Given this list of marker genes MT-ND3, AP3B2, PCDH15, NEK2 (NIMA related kinase 2), TOPORS, RP2, FDXR, PEX19, IMPDH1, PANK2, IFT27, PRPH2, FOXJ1, MT-ND6, HSD17B10, HGSNAT, ZNF513, MYO6, ATP5F1A, CTSD, MAPKAPK3, CEP290, IFT74, CCDC28B, DNAAF6, EYS, PEX5, ATP5MK, TRNT1, SEMA4A, DNAAF11, SDCCAG8, TMEM67, USH1G, BBS9, NPHP4, MAK, SAG, WARS2, MT-ATP8, NDUFA1, OFD1, RSPH9, TELO2, ABCA4, DYNC2I2, HSPD1, MTTP, AMACR, FSCN2, ZNF408, RRM2B, PDE6B, DNAI1, RPGR, GATA3, RPL10, PEX16, RSPH3, CC2D2A, DRC1, ODAD2, PEX12, KIF5A, MCIDAS, GRK1, PEX13, MKKS, PROM1, PEX7, DPAGT1, SLC7A14, LZTFL1, PRPF4, RSPH1, ATP5F1D, GNAT1 (NCBI Gene Id 2779), STK36, FAM161A, CWC27, DHDDS, ATP5F1E, BBS5, BCS1L, DNAAF1, CFAP418, NME8, DHX38, MT-ND1, COQ2, ATP2B2, MT-ND2, IMPG2, BBIP1, PMM2, CFAP300, PEX1, ABHD12, SPAG1, MT-ATP6, CFAP410 (cilia and flagella associated protein 410), PDE6G, TTC12 (NCBI Gene Id 54970), RPE65, DNAH1, ARL2BP, ODAD1, CIB2, PRCD, NRL, NEK10, PEX10, ADGRV1, PEX11B, PEX2, PEX6, RDH11, KIZ, MT-TL1, AGBL5, DNAJB13, MDH2, ODAD3, AHR, GAS2L2, ALG6, MT-ND4, DNAAF2, GUCA1B, BBS10, PRPF31, CNGB1, PRPF3, PEX14, LRRC56, MERTK, CCDC39, CFAP74, SNRNP200, RP9, EXOSC2, PCARE (photoreceptor cilium actin regulator), GGCX, REEP6, SPEF2, RBP3, PRPF6, CFAP298, CFAP221, ACBD5, BBS12, CCDC40, NME5, PEX26, KIF3B, ARL2, RLBP1, CLRN1, RP1, PEX3, TRIP13, BEST1, VWA8, ROM1, BBS1, APOB, DNAH9, TULP1, DNAAF4, SLC35A2, RGR, USH1C, WHRN, RSPH4A, NR2E3, BBS7, PHYH, RHO, CRB1, PDZD7, ZMYND10, ARL3, CRX (NCBI Gene Id 1406), CLN3, HK1, TTC8, PRPF8, CDHR1, MYO7A, SH2B1, ATPAF2 (NCBI Gene Id 91647), DNAAF5, POGZ, HMX1, ODAD4, AIPL1, IFT172, CERKL, DNAH11, DNAH5, DNAL1 (NCBI Gene Id 83544), IDH3B, PPP2R3C, LAMB2, TRAF3IP1, IFT140, MT-TK, MT-TW, ARL6, BBS2, FLVCR1, MSRB3, KLHL7, PDE6A, SRD5A3, BBS4, MT-TV, MKS1, ACOX1, ATXN2, CNGA1, WDR19, DNAAF3, USH2A, DNAI2, NDUFA9, MVK, LRAT, IQCB1, PRPS1, HYDIN, CCNO, MT-ND5, CLDN19, ASPA, CDH23, here is a description of the gene set: species: Homo sapiens Rod-cone dystrophy Human Gene Set: HP_ROD_CONE_DYSTROPHY An inherited retinal disease subtype in which the rod photoreceptors appear to be more severely affected than the cone photoreceptors. Typical presentation is with nyctalopia (due to rod dysfunction) followed by loss of mid-peripheral field of vision, which gradually extends and leaves many patients with a small central island of vision due to the preservation of macular cones.